Given this list of marker genes PDGFA, HMOX1, ZNF449, APOE, SPRY4, TCF25, ZBTB5, SRXN1, PRDM15, MGA, DCX, RBP1, DSCAM, ARL8B, METRN, ELAVL3, PDLIM4, CGREF1, TNFRSF12A, PPP1R1A, EGR1, NIF3L1, SPARC, ABCA1, HMGA1, ESD, KDM6B, LIMS2, SYT12, TIMP1, IGF2R, ADAT2, NTNG1, here is a description of the gene set: studied in species Mus musculus A series of transcription factors critical for maintenance of the neural stem cell state have been identified, but the role of functionally important corepressors in maintenance of the neural stem cell state and early neurogenesis remains unclear. Previous studies have characterized the expression of both SMRT (also known as NCoR2, nuclear receptor co-repressor 2) and NCoR in a variety of developmental systems; however, the specific role of the SMRT corepressor in neurogenesis is still to be determined. Here we report a critical role for SMRT in forebrain development and in maintenance of the neural stem cell state. Analysis of a series of markers in SMRT-gene-deleted mice revealed the functional requirement of SMRT in the actions of both retinoic-acid-dependent and Notch-dependent forebrain development. In isolated cortical progenitor cells, SMRT was critical for preventing retinoic-acid-receptor-dependent induction of differentiation along a neuronal pathway in the absence of any ligand. Our data reveal that SMRT represses expression of the jumonji-domain containing gene JMJD3, a direct retinoic-acid-receptor target that functions as a histone H3 trimethyl K27 demethylase and which is capable of activating specific components of the neurogenic program. Human Gene Set: JEPSEN_SMRT_TARGETS from publication Jepsen K, Solum D, Zhou T, McEvilly RJ, Kim HJ, Glass CK, Hermanson O, Rosenfeld MG (PMID 17928865) Genes up-regulated in neural progenitor cells (NPC) isolated from E13 cortical tissue of SMRT knockout mice.